Given this list of marker genes KIF20A, DLEU1, LAPTM4B, PTBP1, CDKN3, ANAPC5, GLUL, UCP2, CTSC, PDCD4, CCNB1, CLN3, MAP2K2, TMEM14A, PEBP1, MCCC2, CANX, PTGES, PARP1, BIN1, FAHD2A, BIRC5, KCNQ2, LAMP1, TMED2, SPINK5, METRN, ADAM15, UBE2S, HSPA8, POLD1, HNRNPL, PEG10, HNRNPA0, ACOT7, NR2F6, DLGAP5, EFEMP1, MTARC1, TMEM97, LSM2, LY6E, SKP2, SIGMAR1, MRPS12, MLEC, ATP5F1D, ARRB2, GCSH, here is a description of the gene set: Microarray RNA gene expression profiling analysis has shown that Sox4 (Sry-related high mobility group (HMG) box 4) is one of the most upregulated genes in adenoid cystic carcinoma (ACC), relative to non-neoplastic tissue of origin. Here, we show that Sox4 protein is similarly upregulated in ACC by immunohistochemistry of 28 primary cancers and 20 normal tissues. To elucidate the functional significance of these findings, RNA interference (RNAi)-mediated RNA silencing was used to downregulate Sox4 expression in the ACC-derived cell line, ACC3. With confirmed knockdown of Sox4 protein, cell viability was reduced by 51%, with a corresponding increase of apoptosis to 85% as compared to 12% in controls. Apoptosis was confirmed by cell morphology, DNA fragmentation and flow cytometry. Cells could be rescued from the proapoptotic effects of Sox4 RNAi by co-transfection with a construct expressing functional Sox4. Microarray gene expression profiling of RNAi knockdown experiments shows that downregulation of Sox4-modulated expression of critical genes involved in apoptosis and cell cycle control. Overall, our findings suggest that Sox4 contributes to the malignant phenotype of ACC cells by promoting cell survival. from publication Pramoonjago P, Baras AS, Moskaluk CA (PMID 16636670) studied in species Homo sapiens Genes down-regulated in ACC3 cells (adenoid cystic carcinoma) after knockdown of SOX4 by RNAi. Human Gene Set: PRAMOONJAGO_SOX4_TARGETS_DN